The following is a description of a gene set: studied in species Homo sapiens A protein complex facilitating transport of molecules (proteins, small molecules, nucleic acids) into, out of or within a cell, or between cells. Human Gene Set: GOCC_TRANSPORTER_COMPLEX, and this is the list of marker genes: KCNJ9, CACNG3, SCNN1A, COX7C, CACNG8, ATP5F1B, LRRC38, ATP1B4, NDUFA11, KCNA1, SCNN1G, ATP5F1A, KCND1, KCNK4 (potassium two pore domain channel subfamily K member 4), GRIK4, CHRNA6, CACNG4, GRIA3, PLN, CHRNA4, CPT1C, CLCNKA, KCNA2, COX6B2, CLCC1, FXYD2, MT-CO1, TIMM8A, GRIN3A, NDUFA9, TMEM262, KCNK7, UQCRC1, SCN2B, KCNG4, ATP1A4, KCNK16, LRRC52, KCNF1, CLCN1, CLIC6, GRIK1, KCNC4, EPS8, GABRR1, TMEM199, TRPC4, ATP4B, CHRNA3, CACNB1, ATP1A3, KCNAB1, CHRNA10, UQCRHL, CACNA1H, KCNA3, ATP5PO, FXYD1, UQCRH, ATP6V0E1, AMIGO1, LRRC55, KCND2, KCNE2, CACNA2D3, KCNQ4, GABRA5, PEX13, ATP5ME, ATP6V0A2, KCNJ3, CHRNA5, DLG4, ATP6V1H, SESTD1, ABHD6, ANO1, CHP1, NDUFAB1, CACNA2D4, GRIK5, PKD2L1, TRPV5, KCNIP3, PEX14, CACNA1S, CHRFAM7A, RYR3 (ryanodine receptor 3), KCNIP4 (potassium voltage-gated channel interacting protein 4), TIMM13 (translocase of inner mitochondrial membrane 13), ATP5F1EP2, SLC9A1, GRIN2A, C15orf48, CALM2, ATP11C, ATP8A1, MT-CO2, CNGB3, GPR89A, KCNIP2, ATP11B (ATPase phospholipid transporting 11B (putative)), KCNJ13, KCNIP1, HTR3C, MT-ND3, ANO6, CCDC51, STXBP5, SCNN1B, NDUFS5, ATP5MG, NDUFB2, GRIN3B, UQCRFS1P1, GLRB, STX1A, MT-ND1, NDUFB6, NDUFS3, COX5B, WDR93, HCN3, ATP6AP1, PKD1L1, COX8C, CACNG7, BCS1L, KCNH3, KCNH8, LRRC8D, KCNG2, PACC1, KCNH2, GABRP, MT-ATP8, NDUFB8, TTYH2, CCDC115, CACNA1B, ATP5MC3, GRIK2, TRPM5, SCN1B, HSPA2 (NCBI Gene Id 3306), KCNJ6, TRPC1, GABRD, SCN2A, ATP8B4, ATP2A1 (NCBI Gene Id 487), CACNA1G, ABHD12, BEST1, CATSPERB, TPCN2, KCNE3, PTK2B, CHRNB4, UQCRFS1, NDUFC2-KCTD14, ATP5F1C, CLDN4, UNC80, RNASEK, GABRR3, BEST4, GABRG1, ATP5MK, ATP6V0C, NDUFC2, KCNJ16, ATP6V0E2, GRIA1, KCNA6, CACNA2D2, ATP6V0D1, KCNH1, NDUFS1, PORCN, KCNC2, COX7A2L, HCN4, DLG2 (discs large MAGUK scaffold protein 2), ATP5MC2, ATP10A, MICU3, TRPC3, CACNG2, CLIC3, NDUFA4, KCNH6, SCN11A, NDUFB11, OLFM3, CALM1, CACHD1 (NCBI Gene Id 57685), CATSPERD, ATP1B2, FKBP1A, CHRNE, CLCN2, GRIN2B, KCNAB3, CNGA4 (NCBI Gene Id 338753), STAC3, ATP5MJ, PKD2, NDUFA3, KCNJ12 (potassium inwardly rectifying channel subfamily J member 12), TMEM30A, COX7B2, TMEM249, MICU2, KCNQ3, MT-ND2, ERGIC2, SHISA9, NDUFA12, HTR3B, GRIA4, KCNJ5, SCN10A, CACNG6, LRRC8E, ATP6V1G2, NDUFB7, ATP6V1D, CACNA1I, SMDT1, VAMP2, UQCR11, CHRNG, COX4I2 (NCBI Gene Id 84701), GLRA2, MT-ND6, C2CD6, ABCC9, ATP6V0A1, ATP6V1B2, KCNA5, GABRE, HTR3E, CACNA1A, ATP2A2, GABRA3, PKD1L3, CHRNB2, MT-CYB, SCN1A, ABCC8, ABCG8, GABRB2, HCN2, TTYH1, TRPM4, TCIRG1, COX6B1, ATP5MGL, KCNMB2, TMEM30B, KCNK2, ATP8B3, KCNJ11, SHISA6, MCU, COX8A, GABRB1 (gamma-aminobutyric acid type A receptor subunit beta1), ATP5MC1, KCNJ10, ATP1B3, GABRA2, KCNJ8, GLRA1, ZACN, KCNV1, COX7A2, CHRNB1, NDUFV2, KCNN1, KCNAB2, CLCNKB, ATP6V1F, GABRA1, COX6A2, KCNG3, NDUFV1, CNGA2, KCNQ1, KCNQ2, AKAP9, NDUFA7, PRKACA, KCNH7, OLFM2, GRID2, KCNS2, GRIA2, NDUFA13, EFCAB9, GABRQ, GRID1 (glutamate ionotropic receptor delta type subunit 1), KCNK17, CHRNB3, TRPC5, KCNC3, TIMM10, NDUFB4, GABRA6, SCN4A, CATSPERZ, ATP5PB, CNIH2, UQCRC2, MT-CO3, KCNH4 (NCBI Gene Id 23415), MCUB, ABCD4, SCN7A, CATSPER2, KCNK10, ATP1A1, CLIC5, NDUFS2, NDUFB5, COX5A, KCNV2, PEX12, ATP8B1, KCNJ2, CFTR, KCNMB1, CHRNA1, MTCO2P12, CALM3, DMAC2L, BEST3, TRPV6, KCNB2, NDUFS4, CHRNA2, PTPA, NDUFA6, GABRR2, BEST2, SCN5A, RYR2, CHRND (NCBI Gene Id 1144), GRIN1, KCNMB4, KCNS3, ATP1A2, CLDN17, ATP6V1C2, NDUFS6, NDUFA2, KCNS1, SCN8A, ATP6AP2, KCNA7, KCND3, CATSPERG, GLRA3, CNTNAP2, COX6A1, MT-ND4, MT-ATP6, ATP6V0B, CYBB, NALCN, NRN1, ATP6V1B1, COX7A2P2, ANO2, ABCA2, KCNA4, ATP10D, HCN1, TIMM9, ERGIC3, KCNE1, NDUFS8, CNGB1, CACNG5, KCNJ15, CACNB4, GRIK3, CTTN, ATP6V1G3 (NCBI Gene Id 127124), CHRNA7, TPCN1, NDUFS7, SCN4B, SLC17A6, MT-ND5, AKAP6, COX7A1, SLC17A7, CNGA1, HTR3D, ATP6V1G1, CYC1, KCNH5, CACNB3, KCNK12, CACNA1C, TTYH3, CACNA1E, LRRC8C, MICU1, NDUFA8, TIMM8B, PDE4D, ATP5F1E, KCNJ18, ATP5MF, FKBP1B, CNIH3, ATP6V1C1, CASQ2, ATP6V0D2, ATP1B1, KCNE4, VWC2, SLC2A1, CHRNA9, OSTM1, ATP8A2, UQCRQ, NDUFA10, TMEM109, TRPC6, KCNA10, LRRC8A, ATP6V0A4, CNGA3, GRIN2C, COX6C, DPP10, SHISA7, HVCN1, LRRC26, LRRC8B, DLG3, ATP12A, GPR89B, UQCR10, CLIC2, CLIC1, SCNN1D, CLIC4, ABCG5, NDUFB9, NDUFC1, PKD1, ATP5PD, SCN3B, COX4I1, ASPH, SCN9A, NDUFA5, ATP6V1E1, SHISA8, NDUFB1, KCNK1, ORAI1, KCNG1, PDE4B, GABRG3, SCN3A, KCNJ14, SLC17A8 (solute carrier family 17 member 8), GRIN2D, KCNMB3, TIMM10B, GABRG2, KCNK6, SUMO1, MFSD8, ATP10B, SPAAR, KCNU1, UQCRB, NDUFB10, MT-ND4L, DPP6 (NCBI Gene Id 653748), TRPC7, ABCB6, KCNC1, KCNMA1, VWC2L, KCNE5, RYR1, CATSPER3, KCNK5, SACM1L, CACNB2, KCNJ1, CACNA2D1, KCNB1, HTR3A, ATP11A, CATSPERE, KCNK15, CACNA1F, CLCN7, ATP5PF, CATSPER1, CATSPER4, KCNN4, NDUFA1, NDUFAF2, NDUFA4L2, KCNQ5, KCNK13, ATP5F1D, ATP8B2, NDUFV3, NDUFB3, CACNA1D, KCNJ4, GABRA4, ABCB8, ATP4A, SNAP25, ATP6V1A, CACNG1, SLC26A6, GABRB3, COX7B, TMEM37, S100A9, FXYD4